The following is a description of a gene set: from publication Wakabayashi K, Okamura M, Tsutsumi S, Nishikawa NS, Tanaka T, Sakakibara I, Kitakami J, Ihara S, Hashimoto Y, Hamakubo T, Kodama T, Aburatani H, Sakai J (PMID 19414603) Control of cell differentiation occurs through transcriptional mechanisms and through epigenetic modification. Using a chromatin immunoprecipitation-on-chip approach, we performed a genome-wide search for target genes of peroxisome proliferator-activated receptor gamma (PPAR gamma) and its partner protein retinoid X receptor alpha during adipogenesis. We show that these two receptors target several genes that encode histone lysine methyltransferase SET domain proteins. The histone H4 Lys 20 (H4K20) monomethyltransferase PR-Set7/Setd8 gene is upregulated by PPAR gamma during adipogenesis, and the knockdown of PR-Set7/Setd8 suppressed adipogenesis. Intriguingly, monomethylated H4K20 (H4K20me1) levels are robustly increased toward the end of differentiation. PR-Set7/Setd8 positively regulates the expression of PPAR gamma and its targets through H4K20 monomethylation. Furthermore, the activation of PPAR gamma transcriptional activity leads to the induction of H4K20me1 modification of PPAR gamma and its targets and thereby promotes adipogenesis. We also show that PPAR gamma targets PPAR gamma2 and promotes its gene expression through H4K20 monomethylation. Our results connect transcriptional regulation and epigenetic chromatin modulation through H4K20 monomethylation during adipogenesis through a feedback loop. studied in species Mus musculus Mouse Gene Set: WAKABAYASHI_ADIPOGENESIS_PPARG_RXRA_BOUND_8D Genes with promoters bound by both PPARG and RXRA at 8 day time point of adipocyte differentiation of 3T3-L1 cells (preadipocyte)., and this is the list of marker genes: Yap1, Pex3, Zcchc7, Ube4b, Slc2a4, Hoxc8, Hipk1 (NCBI Gene Id 68849, homeodomain interacting protein kinase 1), Uchl3, Ndel1, Taldo1, Nudt12, Pphln1, Cav2, Ccdc134, Ears2, Zfp768, Derl1, Stat5a, Gabpa, Tns2, Emc2, Dnajc19, Pisd-ps1, Hmox1, Gab2, Hjurp, Rrp9, Adat2, Tmem33, Phpt1, Csnk1g2, Atpaf2, Cep44, Ift70b, Gabarapl1, Upp2, Tmem87a, Mid1ip1, Msto1 (misato 1, mitochondrial distribution and morphology regulator), Hcfc1, Cks1b, Stard13, Ghitm, Bbs12, Ift70a1, Kdm1b, Snai3, Calcoco1, Utp14b, Pou6f1, Zfp386, Tnip1, Ndufs4, H2bc21, Fbxo31, Rasa3, Adtrp, Acadm, Ephx2, Gsn, Gm14296, Dgka, Ypel5, Hspa5, Tsga10, Mnd1, 2510039O18Rik, Tmem116, Hnrnpf, Pole, Ptpn6, Fibp, Mtarc1, Bsg, Cpsf4l, Rtf2, Slc25a46, Slc19a2, Nlrp4a, Lamc1, Pcsk4, Abcb9, Grhl1, Drc3, Pfkl, Zfp87, Nup85, Zfp273, Mmd, Acox1, Adam1b, Idh1, Qtrt2, N4bp3, Traf3ip2, Adipoq, Dram2, Csad, Eef2, Idh3a (isocitrate dehydrogenase 3 (NAD+) alpha), Il17rb, Cfap210, Pdia4, Kat2b, Stag1 (NCBI Gene Id 20842), Hoxa1, Pparg, Bnip3l, Chuk, Phyhipl, Hyal2, Chp1, Limk2, Ttc41 (tetratricopeptide repeat domain 41), Pttg1ip, Cox8b, Slc35b4, Mrap, Ppm1b, Pigx, Ubxn6, Mbnl1, Bet1, Stk3, Trp53i13, Psmd4, Hic2, Plin1, Zfp637, Gfer, Myl4, Ctnnbl1, Crtc2, Mars1, Usp6nl, Cd151, Lmna, Reep6, Mxd1, Ilvbl, Acsl3, Ndufs6, Adhfe1, Ggnbp2, Ranbp2 (RAN binding protein 2), Cspg4, Dnajc15, Pcbp2, Ccl1, Xdh, Cavin1, Suclg1, G6pc3, Sp2, Samd8 (sterile alpha motif domain containing 8), Plekhf2, Ttyh2, Ubqln1, Hsd17b12, Prx, Srsf4, Pex16, Il15ra, Kbtbd12, Dedd (NCBI Gene Id 21945), Hsp90b1, Mdm2, Ksr1, Sypl1, Pam16, S100a13, Cfap96, Lrrc41, Nr1h3, Fah, Slc39a13, Ubl5, Ubp1, Rbm4b, Kti12, Map3k12, Hoxa3, Ldhb, Dlst, Ltbp3, Uqcrh, Bahcc1, Hsd11b2, Prpf4b, Gas2l2, Gid4, Lmbr1, Gnai2, Bcl6, Fndc3b, Pex11g, Aox1, Fitm2, Nit1, Mgst1, H2bc4, Plod3, Lzts2, Gadd45a, Eeig1, Ucp1, Nphp3, Abhd12, Klf15, Scd1, Cenpk, Ubfd1, Abhd15, Amhr2, H1f8, Tank, Pla2g6, 4931406C07Rik, Jagn1, Mapkbp1, Fads2, Ltc4s, Zcrb1, Cd53, Anxa7, Letmd1, Amer1, Elmod3, Ncbp1, Hoxa4, Aspa, Loxl1, Cdkn1a, Fgf2, Cd99l2, Acaa1a, Gstt3, Lsm12, Ifrd1, G3bp2, Ptp4a2, Fnip1, Zbtb38, Snn, Selenop, Pex14, Zfp219, Acads, Dab2ip, Zmynd8, Phospho2, Mkln1, Ppm1k, Cpt1a, Zfyve21, Creb3l4, Dusp13b, Oxsr1, Fabp4, Negr1, Tbcd, Tmem140, Slc45a4, Ap5s1, Acadl, Fth1, Mpst, Mycbp2, Pex11a, Hcfc1r1, Msmo1, Ptbp1, Spring1, Ganc, Btf3l4, Coq3, Atn1, Clcn2, Ppcs, Gpd1, Fbxo8, Dnajc5b, Pan2, Cln3, Cyrib, Pdp2, Pcx, 2810408A11Rik, Marchf5, Stat6, Zbtb32, Rmnd5a, Tspan12, Kcnk7, Prkra, Atp5pf, Scarb2, Nek6, R3hdm1, Il31ra, Nup188, Xlr3a, Tead4, Slc25a25 (NCBI Gene Id 68663), Gm14325, Adcy6, Zswim3, Lgals12, Polr3h, Zmynd12, Igsf6, Cmss1, Slc66a3, Mustn1, Ubr5, Klf11, Rnpep (NCBI Gene Id 215615), Ormdl3, Nipbl, Rassf6, Lpl (lipoprotein lipase), Ndufc2, Fam13a, Tpt1 (tumor protein, translationally-controlled 1), Pde12, Arfrp1, Rpn1, Bcar1, Abcb8, Sctr, Gnpnat1, Sf3b3, Rhbdf1, Rras, Mlkl, Eif4ebp2 (eukaryotic translation initiation factor 4E binding protein 2), Emc9, Ccng2, Parl, Cmbl, Wdr18, Nat10, Npc1, Flad1, Hibadh, Rnf4 (ring finger protein 4), Atp6v0c, Cdk13, Odad3, Car4, Tcaf1 (NCBI Gene Id 77574), Slc26a6, Grpel1, D5Ertd579e, Lipe, Cerk, Ptgr2, Hdgfl2 (HDGF like 2), Tob2, Pck1, Acyp2, Dlg4, Tiparp, Tmem254, Aldh6a1, Itsn1, Nr1d1 (NCBI Gene Id 97769), Large2, Ndufa5, Adig, Cmpk1, Rps2, Adck5, Eif4enif1, Tmed5, Plaat3, Sycp2, Slc25a39 (solute carrier family 25, member 39), Tmem175, Neurl4, Hsd11b1 (hydroxysteroid 11-beta dehydrogenase 1), Angptl4, Aftph, Mrps33, Baz1b, Mamdc4, Siva1, Tmco4, Elavl1, Asph, Evi5l, Cma1, Bfar, Cartpt, Siglec1, Mbd6 (NCBI Gene Id 28087), Nr2f2 (nuclear receptor subfamily 2, group F, member 2), Tubb4b, Zfp740, Gtpbp3, Pla2g15, Ehbp1l1, Nfib, Prox2, Pex10, Etfb, Tbxas1, Cst3, Lonp2, Rmdn3, Immt, Cenpi, Myd88, Agpat2, H3c4, Il2ra, Tex19.1, Ces1e, Plac9, Prnp, Snrpd3 (small nuclear ribonucleoprotein D3), Pfkfb1, Tom1l2, Tomm70a, Elf3 (NCBI Gene Id 13710), Tcf7l2, Utp6, Cpeb3, Bcl2l10, Dcst1, Isoc2b, Lgals7, Inpp1, Incenp, Poln, Ccdc85b, Agrp, Slc38a7, Cd36, Agpat1 (NCBI Gene Id 55979), Usp5, Chpt1, Riok3, Gpt, Abi1, Echdc1, Tef, Abcd3, H4c8, Zfat, Pitpnm1, Csnk1d, Pold4, Zfp58, Txlna, Qdpr, Ppp2ca, Ap3s1, Amdhd2, Shc1, Casp8, Atat1, Spatc1, Otud5, Uck1, Kmt2b, Mre11a, H2ax, Phf5a, Gigyf2, Lrrc8d, Cish, Col4a1, Tbl2, Ubxn8, Eef1e1, Canx, Ppip5k1, Slc1a5, Wdr45, Mlf2, Mink1, Ufsp2, Txndc12, Slc5a6, Ucp2, Fdx1, Unk, Chic2, Kat7, Srebf2, Akt1s1, Selenoi, Cpne1, Slc22a12, Oplah, Haus3, Bcat2, Spg21 (SPG21, maspardin), Sec22c, Gcsh, Bcl2l13, Reep5, Mpc2, Eci2, Edc3, Zdhhc3, Cs, Rbck1 (NCBI Gene Id 99156), Dap (death-associated protein), Qki, Pnrc1, Atp5mc3, Msra, Xrcc3, Arhgap29, Cdc27, Proc (NCBI Gene Id 19123), Gpr152, Atg12, Coq8a, Emc6, Hpgd (hydroxyprostaglandin dehydrogenase 15 (NAD)), Gars1, Tmt1b, Pnpla2, Adamts12, Tmem131, Chchd3, Snx33, Capn3, Atg101, Lmbrd1, Pdgfrl, Pimreg, Mlst8, Mgat4b, Pus10, Ppp2r2a, Pank3, Mpp7, 2410018L13Rik, Sort1, Zranb3, Pspc1, Lgals3bp, Setd5, Txnip, Alad, Rack1, Mrpl36, Slc5a7, Sf1, Psma5, Polr2h, Rarres2, Pim3, Trit1, Net1, Alg14, Asb15, Btd, Rbm12, H3c15, Erp29, Pdgfra, Dennd4b, Etv3 (NCBI Gene Id 99611), B3gnt4, Pcca, 2210408I21Rik, Bub1b, Exd1, Zeb2, Tst, Nabp1, Ost4, Eif4ebp1, Tmem216, S100a1, Slc48a1, Lin52, Esrra, Sncg, Cyth1, Abcc4, Whamm, Ldlrad3, Tpmt, Ppp1r15b, Ripk3, Snx10, Cdc25a, Calhm6, Dpp3, Tor4a, Preb, Selenok, Tia1, Naaa, Acaa2 (NCBI Gene Id 68343), Esyt1, Dgat1, Adck2, Gapdh, Acot8, Cblb, Sipa1l1, Iba57, Cryzl1, Nfkbiz, Ifngr1, Eppk1, Pdha1, Pxmp2, Zfp655, Pxmp4, Lif, Mcm7, Hgh1, Atf1, Sspn, Il13, Parp3, Cpa5, Ccdc18, Acadvl, Pex5, Asah1, Smyd3, Prkci, Dynlrb1, Dusp19, Epb41l2, 9030619P08Rik, Mrpl10, Exoc6, Sec24b, Utp3, Fadd, Zdhhc18, Impdh1, Fam13c, Rrp1b, Ttl, Ppwd1, Rnf6, Baz2a, Traf2, Hacl1, Lrp6, Fam3c, Rnf5, Traf7, Scaf1 (SR-related CTD-associated factor 1), Capn2, Stambpl1, Slc25a10, Plpp6, Rnaset2b, Tmem259, Il17rc, Ndufs8, Cidec, Calu (calumenin), 3110009E18Rik, Ripor1, Eif4g3, Stom, Lenep, Eif1a, Pdpk1, Zgpat, Gosr1, Irf2bpl, Ankrd33, Tnpo3, Mtus1, Ginm1, Ubd, Lim2, Etfrf1, Myo1c, Specc1l, Zfp1006, Samd4, Atxn10, Agbl5, Gsto1, Rnft1, Cers4, Fmr1, Scoc, Anxa1, Zfp874b, Lnpep, Hadh, Zbtb14, Kdm6b, Mprip, Eci3, Nid1, Atosa (atos homolog A), Ehmt2, Creb3l2, Efr3a, Spata6l, Cept1, 2010003K11Rik, Ccdc50, S100a3, Rbm43, Upb1, Clec10a, Ap4m1, Pym1, Msh4, Sema4a, Natd1, Arrdc2, Nfe2l1, Gprc5b, Tgif1, Tnfaip2, Itprip, Arid5b, Mocs2, Pcyox1, Dlc1, Emilin1, Mettl9, Spaar, Trappc5, Camk1, Capn9, Usp53, Adipor2, Luzp1, Fbxl12, Aifm2, Noxo1, Dnajc28, Abhd1, Orc5, Pbx2, Mylk, Ddo, Thrsp, Azin1, Tmem134, Syngr4, Kat14, Zfp97, Rab9, Zfp326, Il34, Tmem120a, Mob1a, Nmt1, Sec24d, Sfxn1, Lime1, Echs1, Rgs19, Ganab, Nr2f1, Lipt1, Slc37a3, Prxl2a, Armc8, Serpine1, Cep120, Ilrun, Arf4, Lmntd1, Stat1, Atp1b3, Ntn1, Taf15, Cdca3, Lrrc39, Paox, Sec24c, Ece1, Fndc8, Pkd2l1, Hivep3, Gpat4, Snai2, Txlng, Tarbp2, Ebf2, Gsk3a, H2ac18, Bmp2k, Rbms1, Ywhag, Etfdh, Mkx, Rps19, Ywhab, Slc38a10, Ech1, Efna5 (NCBI Gene Id 13640), Ccdc80, Tbc1d15, Tmem168, Atg9b, Arhgef37, Stk40, Hsdl2, Tmem143, Cep19, Ppdpf, Etfa, Ddit3, Coq5, Zfp770, Ccdc87, Klhl25, Nkapl, Trmt44, Ankrd46, Gucd1, Tbc1d13, Mknk2, Tmcc3, Stt3b, Cyb5a, Pex2, Thoc6, Pakap, Myl12a, Taf1d, Znhit1, Cog4, Tenm4, Mtch2, Bcar3, Plod1, Cracr2b, Enox1, Mtdh, Trak1, Hnrnpl, Mmrn2, Ppp1r3c, Cast, Lama4, Aco2, Rab19, Cox14, Prkcsh, Rabep1, Tle1, Mal2, Sh3glb1, H2bc22, Atraid, Plcb1, Vps26c, Tomm40, Cd302, Grcc10, Pnpla8 (patatin-like phospholipase domain containing 8), Cnksr3, Stimate, Apmap, Cimip2a, Hibch, Kmt5a, Tax1bp3, St3gal2, Elmod2, Glo1, Tmem150a, Lsm10